Given this list of marker genes MCM10, BASP1, CAMKK1, ENTPD3, PBX1, CREBL2, ATP6V0B, OLR1, SORBS1, IL12A, CCDC162P, GFI1, MCU, TLR6, SIK3 (SIK family kinase 3), SSC4D, NIPBL, PTPN6, IQSEC1 (NCBI Gene Id 9922), SLC27A4, PARP14, RSAD2, RUNX2, PPP1R3F (NCBI Gene Id 89801), HSD11B1 (hydroxysteroid 11-beta dehydrogenase 1), SSH2, TSC22D3, NCOR1, FMNL3, CHKA, ACSL1, PIAS1, IL23A, CHAC1, IRF2, SLU7, TNRC6B, RALGPS1, SFXN5, IGF2R, SERINC5, SAG (NCBI Gene Id 6295), NRG3, TMEM170A, PIM1, ZNF217, RNF114, MPZL3, IL15, PTPN12, FBXL12, SNED1, ARSG, KBTBD7, MGST2 (microsomal glutathione S-transferase 2), TUT7, SKIL, CD53, SCRG1, NLRP12, MYLIP, AMPD3, VSIR, SEPHS2, SPRY2, ATF1, SERPIND1, ZNF597, CA4, FGD3, GALNT3, FGL2, GSK3A, CHST11, LYSMD3, TSPY1, SLC25A37, IL13RA1, SCHIP1, TSPOAP1, TIRAP, ZFYVE26, IFIT1, TBX6, PIGV, IMMP2L, MRAP, IGF1R, PYGL, MUSTN1, ITSN2, CXCR3, ATP8B4, PLEK, BTG1, ACKR1, ALAS1, NFKBID, NAB1, DOP1B, N4BP1, MGAM, CXADR, KRT86, TSPAN2, GRIN3A, TMEM202, APOBR, SH2D5, BMPR1A, BST1, USP2, CNR2, FHOD1, ATG9A, CHST15, TNF, MAP4K2, NUB1, ENTPD1, ZNF777, BTBD19, CTSE, HSPB7, SLC7A11, TNFAIP2, BID, CCNL2, KLHL6, SP110, SETD1B, SGMS2, UBXN4, CAPNS2, NEK6, NINJ1, TREML2, NT5E, CLEC1B, MTUS1, SCGB1A1, AMN1, CIB3, MAP3K3, SH2D3C, YPEL3, F3, TAF7, SOAT2, CARD10, PRKCG, LDB2, AICDA, GADD45A, CCNL1, NARS2, DAZ2, TAGAP, RASGEF1B, RFX1, SERTAD3, CPD, EBI3, LENG8, KCTD8, PIK3AP1, LRATD1, FGF23, AP1M1, XKR8, PELI1, MAP3K5, CFAP141, SYNJ1, PNPLA7, UBE2B, CCDC146, TUBB1, MRPL33, CXCL11, KCTD13, SNTB2, VAX2, ZCCHC8, LAMB3, CNTN4, CKAP4, KLF10, BRCA2 (NCBI Gene Id 82716), RETREG1, SPIDR, TMCC1 (transmembrane and coiled-coil domain family 1), CD69, PPFIA2, YPEL1, STX11, TNFRSF1B, BCL6, HECW2, NEDD9, here is a description of the gene set: from publication Petersen BC, Budelsky AL, Baptist AP, Schaller MA, Lukacs NW (PMID 22543263) Human Gene Set: GSE36392_EOSINOPHIL_VS_NEUTROPHIL_IL25_TREATED_LUNG_UP studied in species Homo sapiens Genes up-regulated in comparison of eosinophils treated with IL25 versus neutrophils treated with IL25. Many symptoms associated with allergic asthma result from the sequelae of type 2 inflammation. Interleukin (IL)-25 promotes type 2 inflammatory responses, and T2M cells represent an IL-4 and IL-13 producing granulocytic IL-25 responsive population. We used microarrays to characterize the gene expression profile of T2M cells, and compared T2M cells to other inflammatory subsets (eosinophils, neutrophils, and macrophages) in the lungs of mice with IL-25-induced pulmonary inflammation.